The following is a description of a gene set: Macrophage-stimulating protein (MSP) signaling species: Homo sapiens Human Gene Set: WP_MACROPHAGESTIMULATING_PROTEIN_MSP_SIGNALING, and this is the list of marker genes: CDH2, TNF, ELK1 (ETS transcription factor ELK1), CXCL10, NR4A1, DUSP6, CTNNB1, SMAD6, GSK3B, ACTA2, COL4A1, PRKAA2, NDRG1 (N-myc downstream regulated 1), HSPB1, ZEB2 (NCBI Gene Id 9839), VEGFA, PLCG1, MAP2K1, PTK2, PRKCB, CXCL5, FZD1, SOCS3, GAB1, MAPK9, KLK15, PTEN, MST1, ABL1, CLDN1, ZEB1, MAPK14, SNAI2, SOCS1, WNT10B, SLC2A1, PARP1, FN1, IL6, TP53, SLPI, CRKL, RPS6KB1, CDH1, SMAD3, RPS6, IBSP, SMAD2, GRB2, IL1B, CLDN5, AKT1, NFKB1, SRC (SRC proto-oncogene, non-receptor tyrosine kinase), CXCL1, SMAD1, SMAD9, MAPK8, PCNA, MAPK3, MST1R, VIM, PDGFRB, FOS, SHC1, MMP9, RPS6KA3, CSF2, IGF1R, OCLN, DUSP4, MAP2K2, RPS6KA4, BGLAP, IFNB1, SMAD5, ITGB1, DUSP1, KDR, FLT1, PPARGC1A (NCBI Gene Id 10891), RPS6KA1, PDCD4, MAPK1, MTOR, IL10, SP7, HK2, PDPK1, SIX1, CCL2, CSF3, EGR1, RPS6KA5, RELA, CPT1A, TGFB1, LDHA (NCBI Gene Id 3939), NR0B2, CXCL2, PDGFRA, RAF1, TJP1, PIK3R1, ACACA, FGFR1, JUN, CXCL8 (C-X-C motif chemokine ligand 8)